Given this list of marker genes TBCC, SCRN1, PSMD10, CDKN1B, WASHC2C, SAP18, IFI6, SPEN, ASMTL, N4BP2L1, SNW1, POP4, MOAP1, MICB, TAB2, NPC2, CBX7, CALCOCO2, RNF13, NDUFC1, PBX3, FCGR2B, MKRN1, ASAH1, COX7A2, PSMD8, CTDSP2, RABGAP1L, SMC5, LMO4, DDX19A, PLCL2, HMGN4, CCNG2, RAB31, ADARB1, MXI1, YWHAB, TBL1X, TSPO (translocator protein), ING1 (inhibitor of growth family member 1), PLP2, SERP1, ACBD3, PUM1, SMAD2, HEBP2, CTNNA1, DDX1, here is a description of the gene set: studied in species Homo sapiens The usage of the immunoglobulin (Ig) V(H)3-21 gene is associated with poor prognosis in B-cell chronic lymphocytic leukemia (B-CLL) despite V(H) gene mutation status. Many V(H)3-21+ patients also display restricted heavy- and light-chain Ig gene rearrangements, implying a role of antigen selection in disease development. To explore the specific phenotypic/genotypic features among V(H)3-21+ B-CLLs, we compared gene expression patterns in 15 V(H)3-21+ and 24 non-V(H)3-21 patients (11 with unmutated and 13 with mutated V(H) genes) using Affymetrix microarray analysis (approximately genes). A distinct expression profile was identified for V(H)3-21+ patients in contrast to the Ig-unmutated and -mutated groups. By applying different algorithms, the data enabled an efficient class discrimination of the V(H)3-21+ subset based on 27 or genes. A set of genes was sorted out which, using different analytical methods, consistently gave a distinction between V(H)3-21+ and non-V(H)3-21 samples. Several of these genes are involved in regulation of DNA replication/cell-cycle control, transcription and protein kinase activity, which may render the V(H)3-21+ cells with a higher proliferative drive. However, no clear evidence of increased B-cell receptor signaling was found in the V(H)3-21+ group. Altogether, our identification of a specific V(H)3-21 profile may provide insights into the pathogenesis of the V(H)3-21+ subgroup. Human Gene Set: FAELT_B_CLL_WITH_VH3_21_DN Genes down-regulated in samples from B-CLL (B-cell chronic lymphocytic leukemia) with the immunoglobulin heavy chain VH3-21 gene. from publication Fält S, Merup M, Tobin G, Thunberg U, Gahrton G, Rosenquist R, Wennborg A (PMID 15817677)